Given this list of marker genes ERCC4, RAD54L, MND1, BARD1, MUS81, ANKRD31, TERB1, SYCP1, MSH4, NUCKS1, ANKLE1, TEX11, SYCE3 (synaptonemal complex central element protein 3), MLH3, KLHDC3, SLX4, MRE11, TEX19, MSH5, PRDM9 (PR/SET domain 9), HSF2BP, MAJIN, TERB2, EME2, CNTD1, HDAC10, REC8, ATM, RMI1, MEIOB, CENPS, MLH1, DMC1, RAD50, C1orf146, NBN, RNF212B, EME1, CCNB1IP1, TOPBP1, TOP2B, RAD21, SPO11, RNF212, RBBP8, PSMC3IP (NCBI Gene Id 51769), BRME1, SHOC1, UBE2B, RAD51B, TOP2A, MCMDC2, FANCD2, RAD51AP1, TOP6BL, RAD51, UHRF1, UBR2, BRIP1 (NCBI Gene Id 83991), TRIP13, BRCA1, RAD51C, RAD54B, HFM1, FANCM (NCBI Gene Id 57697), RAD51D, CENPX, C14orf39, here is a description of the gene set: Human Gene Set: GOBP_HOMOLOGOUS_RECOMBINATION species: Homo sapiens A DNA recombination process that results in the exchange of an equal amount of genetic material between highly homologous DNA molecules.